The following is a description of a gene set: Any process that results in a change in state or activity of a cell (in terms of movement, secretion, enzyme production, gene expression, etc.) in response to the depolarization of one or more mitochondria. Human Gene Set: GOBP_RESPONSE_TO_MITOCHONDRIAL_DEPOLARISATION species: Homo sapiens, and this is the list of marker genes: ATG13 (NCBI Gene Id 9776), ATG14, AMBRA1, GPS2, BECN1, SQSTM1